The following is a description of a gene set: Human Gene Set: REACTOME_MATURATION_OF_SARS_COV_1_NUCLEOPROTEIN species: Homo sapiens Maturation of nucleoprotein, and this is the list of marker genes: GSK3B, SUMO1, PARP8, PARP9, GSK3A, PARP6, PARP14, UBE2I, PARP10 (poly(ADP-ribose) polymerase family member 10), PARP4, PARP16